Given this list of marker genes RAB6B, FAIM, COL6A5, RN7SKP212, NCK1, UBA5, SLC35G2, NUDT16-DT, RNU6-1174P, BFSP2, CEP63, C3orf36, INHCAP, ACAD11, HMGB3P14, SDHBP1, AFF4P1, NDUFS6P1, CSRP2P2, LINC02014, RNU6-1284P, SNORA58, OR7E21P, RNA5SP140, A4GNT, CEP70, RHO, TMEM108-AS1, MRAS, NPM1P17, LINC01210, ENSG00000300284, SULT1D1P2, NME9, PLXND1, LINC01391, STAG1, HSPA8P9, ATP5MC2P5, MRPL3, NPHP3, KRT8P36, ATP2C1, ATP5MC1P3, RPL31P23, LINC02000, ENSG00000240086, CPNE4, ANAPC13, TRH, DZIP1L, MIR5704, FAM86HP, FAM76AP1, PPP2R3A, HSPA8P19 (NCBI Gene Id 100420049), MAF1P1, SOX14, GAPDHP39, CRIPTOP6, GSTO3P, RNU6-726P, OR7E129P, ESYT3, TOPBP1, MTCH2P1, TMCC1, RAD51AP1P1, PIK3CB, BFSP2-AS1, LINC02004, NPHP3-ACAD11, FOXL2, EEF1A1P25, RPL39P5, LINC02021, SLCO2A1, RN7SL752P, G2E3P1, TF, RNA5SP142, DPPA4P2, RPL7P16, NEK11, KY, IL20RB, RPL23AP40, HMGN1P9, EVA1CP6, TMEM108, ALG1L2, ENSG00000304443, CDV3, DONSONP1, ENSG00000299775, ENPP7P3 (ectonucleotide pyrophosphatase/phosphodiesterase 7 pseudogene 3), AMOTL2 (NCBI Gene Id 51421), ARMC8, PCCB, STAG1-DT, CARMIL2P1, NUDT16, MSL2, FOXL2NB, PSMC2P1, RPS17P9, COL6A6, EPHB1, ACKR4, CLDN18, ACP3, IL20RB-AS1, DBR1, NUDT16L2P, NIP7P2, H1-8, TMCC1-DT, HMGN1P10, SNRPCP8, RNU6-678P, VPS51P10, HMGB3P13, SRPRB, NPHP3-AS1, PPIAP72, COL6A4P2, ACSL3P1, ENSG00000248468, RNU6-789P, ASTE1, DNAJC8P2, RNY3P13, DNAJC13, RNA5SP141, NCK1-DT, RYK, BCL2L12P1, PIK3R4, here is a description of the gene set: species: Homo sapiens Human Gene Set: chr3q22